The following is a description of a gene set: The molecular mechanisms governing self-renewal, differentiation, and lineage specification remain unknown. Transcriptional profiling is likely to provide insight into these processes but, as yet, has been confined to static molecular profiles of stem and progenitors cells. We now provide a comprehensive, statistically robust, and dynamic analysis of multipotent hemopoietic progenitor cells undergoing self-renewal in response to interleukin-3 (IL-3) and multilineage differentiation in response to lineage-affiliated cytokines. Cells undergoing IL-3-dependent proliferative self-renewal displayed striking complexity, including expression of genes associated with different lineage programs, suggesting a highly responsive compartment poised to rapidly execute intrinsically or extrinsically initiated cell fate decisions. A remarkable general feature of early differentiation was a resolution of complexity through the downregulation of gene expression. Although effector genes characteristic of mature cells were upregulated late, coincident with morphological changes, lineage-specific changes in gene expression were observed prior to this, identifying genes which may provide early harbingers of unilineage commitment. Of particular interest were genes that displayed differential behavior irrespective of the lineage elaborated, many of which were rapidly downregulated within 4 to 8 h after exposure to a differentiation cue. These are likely to include genes important in self-renewal, the maintenance of multipotentiality, or the negative regulation of differentiation per se. Human Gene Set: BRUNO_HEMATOPOIESIS from publication Bruno L, Hoffmann R, McBlane F, Brown J, Gupta R, Joshi C, Pearson S, Seidl T, Heyworth C, Enver T (PMID 14701746) studied in species Mus musculus Genes that are rapidly down-regulated as multipotential cells of the FDCP-mix hematopoiesis model undergo differentiation and loose their self-renewal and proliferation properties., and this is the list of marker genes: FKBP1A, TEC, AQP9, RNF19A, CCN3, BHLHE40, CAPN5, SLFN12, PBX1 (NCBI Gene Id 5087), AK1, RCN1, IGFBP7, ANXA2, CTSC, MAP3K1, GLB1, REPS1, SPARC, HK2, GALK1, H2BC4, DHCR7, CRISP3, CPE, SLC39A6, SQSTM1, PFKP, ADGRE1, VAMP5, GZMB, PTGIR, BCL2, ZNF106, ELF1, BNIP3, CALCA, HSD17B10, AK4, PTGS2, NOCT, CCNG2, SPINT1, HMGCR, IL4, MNDA, CCL3, SESN1, CD55, MSMO1, ELOVL6, LAT2, TSPAN32, CD53, TIE1, ENAH, SERPINF1, RBL2 (RB transcriptional corepressor like 2), SCD, FGF3, DAG1, TJP1, SNAP23, CD9, PRDX4, NET1, S100A6, H1-0